Given this list of marker genes Trip13, Ccnb1 (cyclin B1), Wee2, Plcb1, Ednra, Ptk2b, Tut4, Lsm14b, Aurka (aurora kinase A), Bnc1, Ythdf2, Cdc25b, Zar1l, Sirt2, Shb, Edn1, Mos, Pabpc1l, Fbxo5, Pde3a, Washc5, Ppp2r1a, Zar1, Ereg, Brca2, Nppc, Insl3, Npr2, Foxo3, Oosp2, Dmc1, Rec8, Rps6ka2, Rxfp2, Washc1, Dazl, Tut7, H3f3a, Grb14, here is a description of the gene set: Mouse Gene Set: GOBP_OOCYTE_MATURATION species: Mus musculus A developmental process, independent of morphogenetic (shape) change, that is required for an oocyte to attain its fully functional state. Oocyte maturation commences after reinitiation of meiosis commonly starting with germinal vesicle breakdown, and continues up to the second meiotic arrest prior to fertilization.